The following is a description of a gene set: from publication Matzuk MM, Lamb DJ (PMID 18989307) Reproduction is required for the survival of all mammalian species, and thousands of essential 'sex' genes are conserved through evolution. Basic research helps to define these genes and the mechanisms responsible for the development, function and regulation of the male and female reproductive systems. However, many infertile couples continue to be labeled with the diagnosis of idiopathic infertility or given descriptive diagnoses that do not provide a cause for their defect. For other individuals with a known etiology, effective cures are lacking, although their infertility is often bypassed with assisted reproductive technologies (ART), some accompanied by safety or ethical concerns. Certainly, progress in the field of reproduction has been realized in the twenty-first century with advances in the understanding of the regulation of fertility, with the production of over 400 mutant mouse models with a reproductive phenotype and with the promise of regenerative gonadal stem cells. Indeed, the past six years have witnessed a virtual explosion in the identification of gene mutations or polymorphisms that cause or are linked to human infertility. Translation of these findings to the clinic remains slow, however, as do new methods to diagnose and treat infertile couples. Additionally, new approaches to contraception remain elusive. Nevertheless, the basic and clinical advances in the understanding of the molecular controls of reproduction are impressive and will ultimately improve patient care. Meitic and DNA repair genes important for female fertility, based on mouse models with female fertility defects. Human Gene Set: MATZUK_MEIOTIC_AND_DNA_REPAIR species: Homo sapiens, and this is the list of marker genes: CPEB1, IKBKG, ERCC1, CDK2, SYCP2, NOS3, MSH5 (mutS homolog 5), SPO11, SGO2, FANCL, FANCA, TRIP13, ATM, UBR2, TOP3B, NBN, HSF2 (heat shock transcription factor 2), ERCC2, MLH3, SMC1B, SYCP1, UBB, MSH4, MOS, REC8, PMS2, DMC1, GJA4, MLH1, BRWD1, FANCG, GPR3, FMN2, FANCC, SYCP3, CDC25B, MEI1, CKS2, PPP3R1